Given this list of marker genes NDUFA8, MT-ND5, MFSD8, NME2, ENO4, ATP5F1EP2, ADPGK, NUPR1, GCK, MAP2K1 (NCBI Gene Id 5604), NME3 (NCBI Gene Id 96012), MT-ND1, NME1, UCKL1, ENTPD3, CAD, MLST8, RPTOR, MLXIPL, ATPSCKMT, NDUFB10, BEND3, NUDT16, ATP5F1C, NDUFS2, IMPDH1, ATP6V1B1, PPARA, SLC4A4, SDHA, DHTKD1, BAD (BCL2 associated agonist of cell death), COL6A1, PID1, HSPA8, SLC25A25, BLOC1S6, MTCH2, ATP5F1D, FIS1, ATP5MF, PRKAA2, NDUFB5, BPGM, INSR, ATP5MC1, NDUFS8, ABCC9, NDUFA3, RAN, STAT3, NDUFA13, ADK, TMSB4X, MT-ND4L, SELENON, LETMD1, MTOR, ATP5MK, MT-ND4, OLA1, PARG, NDUFC2, ATP5MC3, PARP1, GTPBP1, RHOQ, CLPX, DTYMK, NME7, MYH8, MYH7, ALDOC, VPS9D1, NDUFC1, NME9, DMAC2L, SIRT6, NDUFA1, UQCC3, RAB23, ATP5MC2, NDUFA9, PFKM, SLC25A13, JMJD8, ARL2, NDUFB1, SDHD, NUDT15, NDUFA12, NT5E, ITPA, NDUFB4, VCP, ATP5PF, ADCY10, GAPDH, ATP1A2, ATP5F1E, GAPDHS, NDUFS5, CTPS1, EIF6, NCOR1, AMPD2, PRXL2C, ENTPD7, CBFA2T3, EP300, PGAM4, NDUFA2, LRRK2, CTPS2, NDUFS6 (NADH:ubiquinone oxidoreductase subunit S6), UCHL1, INS, NDUFA7, HSPA1B, PFKFB2, SLC2A6, AK3, TPI1, NDUFA11, PFKP, NDUFB2, DDIT4, NUDT5, IL4, NDUFA10, FBP1 (NCBI Gene Id 2203), NDUFS1, NDUFAB1, UCK1, GNAI3, PPP2CA, ATP5PB, SAMHD1, HIF1A, ALDOB, NDUFB9, ATP6V1A, APP, OGDH, ENPP3 (NCBI Gene Id 5169), OGDHL, MT-ND6, LDHC, ENO2, AK2, NDUFS3, HKDC1, ATP5F1A, TGFB1, KAT2B, CMPK2, MT-ATP8, ARNT, UCP2, ABCC6, PRKAG3, SDHC, GPD1, NDUFS4, ENO1, NDUFB6 (NCBI Gene Id 4712), ACTN3, PRKAG2, MT-ATP6, DNM1L, ATP5ME, PFKFB1 (NCBI Gene Id 5207, 6-phosphofructo-2-kinase/fructose-2,6-biphosphatase 1), ZBTB20, TIGAR, PFKL, SMPDL3A, BCL2L13, ADA, ALDOA, NUDT2, GIMAP7, SPHK2, NME2P1, FOXK1, PGK2, ENO3, TRIM63, PSEN1, PINK1, HSPA1A, FLCN, SLC4A1, UCK2, HK1, PRKACA, ATP5PO, IFNG, PFKFB3, PKLR, FOXK2, CTNS, ENPP1, P2RX7, STOML2, SDHB (NCBI Gene Id 96200), PGM1, ATP5MG, GUK1, NDUFA5, NME4 (NCBI Gene Id 4833), HK2, IER3, ATP5MJ, HTR2A, PRKN, OGT, NDUFS7, TSPO, ATP6V0C, DNAJC30, MIR675, COX11, NDUFV1, NDUFV2, ATP5F1B, FIGNL1, NDUFA6, LDHA (lactate dehydrogenase A), HK3, NDUFB3, TAFAZZIN, MT-ND2, ZBTB7A, NDUFV3, IMPDH2, GIT1, AK5, DUT, DGUOK, TREM2, ATP7A, TBPL1 (TATA-box binding protein like 1), ANTKMT, DCTPP1, AK1, LIPA, EFL1, ATP5IF1, PGK1, OPA1, PKM, HDAC4, FKRP, PGAM2, ATP1B1, TYMS, AK4, ENTPD4, PRKAA1, NDUFB7, RRM2B, NME6, MYH4, NDUFB8, NME5, MT-ND3, SRC, GPI, ATP5MGL, ATP6V1B2, IGF1, NADK, FAM3A, PGAM1, MYH3, GALK1, ATP5PD, NMNAT1, PRKAG1, NDUFB11, MYH6, TREX1, MFN1, here is a description of the gene set: studied in species Homo sapiens The chemical reactions and pathways involving a nucleoside triphosphate, a compound consisting of a nucleobase linked to a deoxyribose or ribose sugar esterified with triphosphate on the sugar. Human Gene Set: GOBP_NUCLEOSIDE_TRIPHOSPHATE_METABOLIC_PROCESS